The following is a description of a gene set: Abnormal increase or decrease of the naive CD4+ T cell subpopulation, commonly characterized as CD45RA+, CD45RO-, or CD27+, measured as percentage of total CD4+ T cells in the blood, compared to a reference range for a given sex and age-group. These cells are sometimes also characterized as CD62L+ and CCR7+. species: Homo sapiens Human Gene Set: HP_ABNORMAL_NAIVE_CD4_POSITIVE_T_CELL_PROPORTION Abnormal naive CD4-positive T cell proportion, and this is the list of marker genes: POLD1, PSMB10, SMARCAL1, PIK3R1, BCL11B, POLD3, SASH3